The following is a description of a gene set: species: Mus musculus part of: Innate Immune System This event has been computationally inferred from an event that has been demonstrated in another species.<p>The inference is based on the homology mapping from PANTHER. Briefly, reactions for which all involved PhysicalEntities (in input, output and catalyst) have a mapped orthologue/paralogue (for complexes at least 75% of components must have a mapping) are inferred to the other species. electronically inferred by orthology from the curated human pathway Reactome Pathway: FXIIa activates plasma kallikrein-kinin system, and this is the list of marker genes: Kng2, Hrg, Plaur, Klkb1, Serping1, A2m, F12, Prcp